Given this list of marker genes NSA2, NMNAT1, CCDC32, RANBP10, MAP4K2, ARID4B, ZSCAN20, VASP, SUN2, MKRN1, MYH9, SESN1, ARL5C, PEX5, CUX1 (cut like homeobox 1), PHYHD1, NANOS1, ACAA2, RNF38, STAMBPL1, EPS15, VEZF1, POLG2, ABLIM1, ACAD8, MFSD8, LONP2, PXN, CNTRL, RSU1, CHD8, ADH1A, MPPE1, IFI27L1, TIMP2, TECPR1, PPP1R9B, ARID1A, FUCA2, SMAD5, ANAPC13, VPS13B, RDH10, RHOG, RIMOC1, IGBP1, ATP6V0B, HECTD3, ACOT13, FUCA1, MTMR3, FBH1, TRIM13, TUSC3, VPS54, EXD2, FHIP1B, ZHX2, CRIP1, CD2AP, GRN, POLR3GL (RNA polymerase III subunit GL), WDCP, ACOX3, ZZEF1, NSD3, ELF4, CALCOCO1, TLR6, ZER1, SEMA4C, PLCG1, SLC66A3, ULK2, DTNB, ASAH2, MCOLN3, ABCA3, KIF21B, B3GAT3, CD3E, TNFAIP8L1, SLCO4A1, TFDP2, LYST, TBXA2R, YPEL3, SYNJ1, PGLYRP1 (NCBI Gene Id 8993), SARAF, DCAF12, RBM46, IRF9, PPM1A, ZFAND1, CD9, SERPINB2, TMEM106B, INPP4A, NCOA1, SYNPO (synaptopodin), FILIP1L, ING3, MTMR12, SLC4A2, ADAMTS10, MSI2 (NCBI Gene Id 124540), ST8SIA4, FBXO25, CCDC92, PLEKHF2, MIR505, ACSS1, LXN, SCAI, MLH3, IL2, MFNG, VPS13A, TMEM63B, ARRDC1, GGA3, SEPTIN6, BBS4, PHYH, AKAP10, RNF41, RIGI, LTB, ARAP1, MIR216A (NCBI Gene Id 406998), SLC25A23, LRCH3, KDELR1, VAMP2, TRIM14, WRN, DRAM2, DSE, SLC17A9, BRAP, MAP3K2, USP25, ADI1, ELMOD2, ESR1, PSD4, CYTH1, FAM120B, GABARAPL2, SPNS1, BRF1, HSDL2, FLI1, REEP3, MBD6, KDM4C, NR2C2, SLC25A45, here is a description of the gene set: from publication Fulcher JA, Hashimi ST, Levroney EL, Pang M, Gurney KB, Baum LG, Lee B (PMID 16785517) Human Gene Set: GSE4984_GALECTIN1_VS_LPS_STIM_DC_UP species: Homo sapiens Human monocyte derived dendritic cells matured via galectin-1 or LPS. Genes up-regulated in monocyte-derived dendritic cells: LGALS1 versus LPS.